Given this list of marker genes Ago1, Gng12, Tent5b, Gnpat, Fmo5, Pafah1b1, Phactr2, Pfn2, Pfkfb3, Pth2r, Milr1, Uqcc1, Wdr41, Nlrp1a, Ap3s2, Dtx4, Ppp1r16b, Etv1, Bcl11b, Cyp4f14, Mocs3, Jchain, Fgd1, Ube3c, Tvp23b, Lats1, Fmnl3, Cnot6l, Zfhx4, Mrps6, Arid4a, Izumo1r, Tob1, here is a description of the gene set: from publication Chen Y, Wang X (PMID 31504780) studied in species Mus musculus Genes predicted to be targets of miRBase v22 microRNA mmu_miR_290b_3p in miRDB v6.0 with MirTarget v4 prediction scores > 80 (high confidence targets). Mouse Gene Set: MIR_290B_3P